The following is a description of a gene set: Human Gene Set: GOBP_CELLULAR_COMPONENT_MAINTENANCE The organization process that preserves a cellular component in a stable functional or structural state. studied in species Homo sapiens, and this is the list of marker genes: APOE, INS, ITGB3, MYADM, SHANK1, MTMR2, ITPKA, PPFIA2, ZMYND8, PKP1, CBLN3, CSMD2, TPRN, NLGN2 (NCBI Gene Id 57555), SYNGAP1, INSR, RAPSN, PLXNA4, PCLO, SDF4, CSF1R, CLRN2, ARF6, INAVA, VPS35, DSC1, CAMSAP3, CFL1, TJP1, ERC1 (ELKS/RAB6-interacting/CAST family member 1), MIR30B, RIMS2, SORT1 (NCBI Gene Id 6272), TREM2, MTSS1, PJVK, DLG1, ITGA3, CLDN1, CNTNAP1, OPHN1, ERC2, LNPK, MYOCD, NEDD9 (NCBI Gene Id 4739), GIT1, CLDN3, CD177, ZNF804A, FERMT2, CHCHD10 (NCBI Gene Id 400916), PARD6A, FYN, PLEKHA7, APP, IGF1R, PRTN3, KIFC3, GRIN2B, RIMS1, ELMOD3, CBLN1, PRNP, KIRREL1, F2RL1, ADGRB3, RIMS3, CTTN, GRN, ABHD17B, PRICKLE1, C1QL1, RAB3A (RAB3A, member RAS oncogene family), FCGR2B, CBLN2, DCTN1, HOMER1, TANC1, F2R, WHRN, PICK1, APPL1, BSN